Given this list of marker genes DES, UNC45B, FXR1, TNNT1, ACTN2, SQSTM1, KY, CFL2, here is a description of the gene set: Z-band streaming Human Gene Set: HP_Z_BAND_STREAMING species: Homo sapiens Streaming or smearing of the Z band, which is then no longer confined to a narrow zone which bisects the I band. The Z disk may extend across the I band or the entire sarcomere in a zigzag manner. Focal thickening, smudging, and blurring of the Z band takes place concurrently. Myofibrillar disorganization is a frequent but not invariable accompanying change.